The following is a description of a gene set: species: Homo sapiens Genes down-regulated in cells sorted as ITGAX int: EMR1 high macrophages versus EMR1 int dendritic cells. Dendritic cells (DCs) and macrophages (MPs) are important for immunological homeostasis in the colon. We found that F4/80hi CX3CR1hi (CD11b+CD103-) cells account for 80% of mouse colonic lamina propria (cLP) MHC-IIhi cells. Both CD11c+ and CD11c- cells within this population were identified as MPs based on multiple criteria, including a MP transcriptome revealed by microarray analysis. These MPs constitutively released high levels of IL-10 at least partially in response to the microbiota via an MyD88-independent mechanism. In contrast, cells expressing low to intermediate levels of F4/80 and CX3CR1 were identified as DCs, based on phenotypic and functional analysis and comprise three separate CD11chi cell populations: CD103+CX3CR1-CD11b- DCs, CD103+CX3CR1-CD11b+ DCs and CD103-CX3CR1intCD11b+ DCs. In non-inflammatory conditions, Ly6Chi monocytes differentiated primarily into CD11c+, but not CD11c- MPs. In contrast, during colitis, Ly6Chi monocytes massively invaded the colon and differentiated into pro-inflammatory CD103-CX3CR1intCD11b+ DCs, which produced high levels of IL-12, IL-23, iNOS and TNF. These findings demonstrate the dual capacity of Ly6Chi blood monocytes to differentiate into either regulatory MPs or inflammatory DCs in the colon, and that the balance of these immunologically antagonistic cell types is dictated by microenvironmental conditions. Human Gene Set: GSE27859_CD11C_INT_F480_HI_MACROPHAGE_VS_CD11C_ING_F480_INT_DC_DN from publication Rivollier A, He J, Kole A, Valatas V, Kelsall BL (PMID 22231304), and this is the list of marker genes: ZMYM3, GRAMD1A, LASP1, CCNG2, TEP1, WDR13, UFC1, INSM2, THY1, PDE4B, PPOX, TGFBR2, AFF4, JAK1, RREB1, GPX3, IL4, CDC42SE2, CLCN4, UQCRHL, HLTF, APCS, PPT1, EDNRB, SYT1 (NCBI Gene Id 6857), ZNF644, COPRS, KCTD12, BTG2, PRKCH (protein kinase C eta), PI4KA, CRLF2, CCNL2, BTBD3, ZNF276 (zinc finger protein 276), VAMP1, RPS9, CTSA, GALNT10, COL18A1 (NCBI Gene Id 80781), PNRC1, IL4R, APAF1, CNPPD1, RANBP10, SEC62, PCDHB6, LIMS2, PDLIM2, ABI1, CUL9, CD53 (NCBI Gene Id 963), ZNRF1, PLEKHF1, ARPC1B, AK3, CASP6, PPP6C, CHD8, ILK, ADAM8, AP3M2, C3orf38, TMPRSS3, ARSA, ECI2, EZH1, PIWIL2, UBL3, CHIC2, MIDN, MAP1LC3B, PLAAT3, COL6A2, SNN, BSCL2, OGA, NR1I2 (NCBI Gene Id 8856), ANKRA2, ATP1B4, HIP1R, RAB4A, FBXW2, BPIFB1 (BPI fold containing family B member 1), LIME1, CAVIN4, EGLN2, RNH1, MBTPS1, RPL19, IL16, PDHA2, RIOK3 (NCBI Gene Id 8780), WDFY1, CCNI (NCBI Gene Id 10983), PITPNM1 (phosphatidylinositol transfer protein membrane associated 1), FN3K, ART4, DAPP1, TK2, SP4, SDCBP2, CMPK1, GCM2, HCST, ARRB1, AKAP8L, EPCAM, SIRT7, PGS1, RAP1GDS1, TMEM229B, PTS, MRTFA, NISCH, GMFG, FYCO1, JUP, YPEL3, CBLN3, PRDM1, CD52, RPS16, CHDH, TSPO, P2RX5, TAOK3, CORO1B, FAM117B, IL24 (interleukin 24), SELENOW, PHF8, GBP4, COLQ, EGLN3, CAV3, ZC3H7A, FERMT3, SELENOV, FAM241B, STX5, SLC15A2, CXCR4, OAZ2, WASHC1, SOX14, PTPN18, SLC38A4, SLC37A3, ARHGAP18, RSRP1, WAS, CSPP1, PACS1, MAP4K2, C5, PCMTD2, TMEM123, SLA2, DOK1, YAP1, RBM39 (NCBI Gene Id 9584), GOLPH3L (NCBI Gene Id 94793), SDF4, MTA3, MRPL9, ALOX12B, RPL27, SLC51A, TMLHE, SHARPIN, TGM2, ADAMTSL5, USP17L2, MAPK8IP3, SLC2A3, SCG5, CTSD, DCAF11, CRLF1, ARHGAP1, TBC1D15, DVL2, MAP3K3, BAZ2A, GJA4, RNF20, RNF208 (ring finger protein 208), SORL1, ING4, DUSP2, ANKIB1, CYBRD1 (cytochrome b reductase 1), RNF19B, SAT1, LRP1, SMPDL3A, RAP2A, ALKBH4, NIPBL